The following is a description of a gene set: Each fraction of mouse hematopoietic cells was purified by cell sorting from bone marrow of 8-week-old C57BL/6 mice, and its gene expression was analyzed. from publication Konuma T, Nakamura S, Miyagi S, Negishi M, Chiba T, Oguro H, Yuan J, Mochizuki-Kashio M, Ichikawa H, Miyoshi H, Vidal M, Iwama A (PMID 21540074) species: Homo sapiens Human Gene Set: GSE27786_LSK_VS_NKCELL_DN Genes down-regulated in comparison of LSK versus NK cells., and this is the list of marker genes: VPS26C, CLK3, STARD5, TRIM69, DMAC1, SORT1 (sortilin 1), CNDP2, ITPRIPL2, SIDT1, SPI1, EML6, RBKS, SNTG2 (syntrophin gamma 2), SSTR4, GAK, PDE7A, NLRC5, SMARCD2, HECA, GAB2, SCT, MLX, RCHY1, DNAJC3, DNAJC1, FOXK1, KCNQ4, SLC37A3, GPR68, GIMAP6, SMDT1, PCBD2, RIGI, PPIB, TWF2, GCNT1, PLA2G2F, STAMBPL1, PLCD1, LRRC8D (leucine rich repeat containing 8 VRAC subunit D), CCDC82, NECAP2, SDHAF2, FZD7, EDF1, PRXL2B, PPP3CC, SUSD6, PTGIR, CRIP1, CDK9, CERS5, PLOD1, MRTFA, DLGAP4, PDE3B, CRNKL1, FOXP1, CYB5R4, CTDSP1, CCDC88B, CITED4, ERO1B, LIMS4, DLGAP2, AP3B1, RETREG3, CARD11, RSAD2, SLC35B1, CCDC9, LY6E, CRYBG1, HTRA2, ABCD1, ABCA7, RTN1, KIAA0930, SNF8, GPR183, TRIR, UCKL1, PGAP1, OTULIN, RBM47, WRN, TMEM161B, JAK2, ARF6, RPL27, TNFRSF1A, TRAPPC8, FAR1, VPS28, ST3GAL6, EGFR, ITGB5, MBNL2, AXL, GLTP (NCBI Gene Id 51228), EAPP, G6PD (NCBI Gene Id 83159), TIFAB, ZHX2, PLEKHA2 (NCBI Gene Id 651347), HEXB, DNAJC17, ESYT2 (NCBI Gene Id 57488), NDEL1, DHPS, CD2AP, POLD4, SP1, OSR1, SNTG1, CEBPB, CPEB4, NRBF2 (nuclear receptor binding factor 2), UBL3, AKAP12, KLF3, SUN2, LRP10, MARK3, AP5Z1, APBB1IP, CHMP4B, EPB41L2, CEMIP, TRIM8, PYCARD, TLR6, MTHFD2, KXD1, CHMP2A, NDUFA13, CCDC124, PTGER2, QNG1, LEF1, NAB1, OLR1, GNG10, LY96, ERRFI1, TTLL3, RINL, ATP5F1E, MKLN1, PDCD4, ACLY, ABCC5, FAM219B, PHF21A, SON, SBNO1, ENPEP, BECN1, AKR1B1, SYS1, AGFG2, CCSER2, NFKBIA, STARD3, DZANK1, SNAPC3, PTPN12, STIM2, TAF12, KIDINS220, TNFRSF25, MED11, RPL18, ATP6V1F, IDS, LSM14A, RELL1, CDIPT, BLOC1S4, PAN3, PLEKHM3 (pleckstrin homology domain containing M3), RRBP1, SLFN13, ZBP1, HAPSTR1, SLC39A3, RIT1, DCAF5, DDI2, MBD2, TNFRSF18, TMEM38B, WAS, DERL1, ARFIP1, HPS5, VPS26A, COMMD6, TUBB2A, RER1